Given this list of marker genes ASXL2, SYTL1, MICB, FGF22, HCRT, NHERF2, IL12A, LRRTM2, FCN2, HDGFL3, DLG3, LILRB1, SMAD3, ITGB7, C1QBP, DOK2, RIMBP3B, TAC3, NOTCH2NLA, RAET1E, FGF14, IBSP, DNAJA1, GNA12, GABARAPL3, PDGFC, IL6, F2RL1, PLXNB1, GNAT2, GPHN, ULBP2, FSHB, KCTD10, SCP2, TRDN, RGMA, FES, LTB, GDF3, VWDE, EFNA1, NMB, ECM2, IRS2, GRAPL, HLA-B, SCT, TGFB2, CD22, RASA1, GABARAP, CD177, PKD2, ARFGEF2, CCL1, ITGA4, NOTCH4, DKKL1, ENG, ARPP19, RIMBP3C, FST, MAF1, IL1RN, GBA1, DEFB106A, BID, SACS, SEMA6D, TMBIM1, HLA-F, TGFBR3L, KCNJ8, ESR2, LRP4, CXCL5, GPHA2, GMFB, LANCL1, ITGAX, ADRA2A, DMP1, GRB10 (NCBI Gene Id 9769), FNDC5, CR2, TAC4, RYK, IFNA10, BTNL10P, REG1A, FAP, WNT8A, MYO9B, S100A4, S100A9, RTP4, BTN3A3, TLR9, RIMBP3, ERBIN, FGF5, PMCHL2, IL17RA, OSGIN2, TUBB3, CHN1, SHANK3, UTS2B, HTR1A, TAP1, GDF9, SRPX2, S1PR2, DLL1, ANGPTL3, BTN3A2, CCKBR, GNRH2, SNX17, CMTM7, APLN, CD74, APOL2, GAST, BEX3, HOMER1, MYH9, BTN2A1, SH2B2, NEO1, ECM1, SLC39A1, ERBB3, GRN, IL36RN, NENF, CTSG, FRMD5, MR1, IGHA1, S100A13, PANX1, NRXN1, AIMP1, CASP8, BCAP31 (B cell receptor associated protein 31), SCGB3A1, CBLB, PLAUR, ERFE, TARM1, NGF, SLURP2, TRAF3IP2, SLC6A3, ELMO2, FZD1, ITGA2B, CD2, DTX1, ATP5F1B, TLR10, ZBTB16, FGF17, PENK, SLIT1, IGHG2, CD3G, HGF, LILRB2, GDF10 (growth differentiation factor 10), GRAP, COL5A1, PDYN, DKK2, ECRG4, GPRASP2, KITLG, CD8B, TGFBR3, EPHB2, ITGAD, NCK1, CASP3, DEFB1, FGF7, MAP3K7, EIF3A, BLK, RNF43, TAFA2, CCRL2, OSGIN1, CD36, MST1L, NCR3LG1, HBA2, DEFB106B, WNT7A, LGALS3, RELN, TAF6, MMRN2, JAKMIP1, WFIKKN1, NOTCH2NLB, SEMA5A, ITGA6, BTN1A1, TNFRSF14, DEFB103B, IL17D, IL7, S1PR3, PPBP, IL36B, CLU, CD8B2, TMED2, STC1, PECR, GDF5, ADAMTS13, ITPRID2, DEFB104B, ARNT2, DLG4, IL34, DUSP3, ULBP3, NPFFR2, SPG21, SEMA4A, SNX4, MUC4, PXN, IFNG, SEMA3G, EREG, SH2B1, AGTR1, PDCL3, NRXN2, ESM1, KLRC4-KLRK1, FRS3 (fibroblast growth factor receptor substrate 3), SPRED1 (NCBI Gene Id 161742), ENHO, TAPBP, CCL2, AKAP9, TNFRSF11B, IFNA7 (NCBI Gene Id 3444), BTNL2, DLG2, LGR6, LRIG2, S100A12, IFNE, EPS8L1, DMTN, IFNA6, TRAK2, PLXNC1, FGF1, CSPG5, NRROS, SOS1, MACC1, ACTN4, ANKRD13C, CASR, TRAK1, RAB8B, SOCS1, DAB2IP, SDCBP, ALCAM, IL27, PEX14, TRAF2, PTH, DDT, OXT (oxytocin/neurophysin I prepropeptide), USP33, LACRT, APP (NCBI Gene Id 351), BMP6, IZUMO1R, TSPAN8, METRNL, RASL11B, WNT9B, ADAM22, PTCH1, NTS, ADAM23, CCL23 (C-C motif chemokine ligand 23), GFRAL, LAMB1, CAV2, GABARAPL2, ISG15, FGF8, NPTN, CDNF, EFNA3, PRKN, REEP2 (NCBI Gene Id 51308), CD300LF, RSPO2, IGF1, APBB3, ITGB2, APOA1, GNA11, PACRG, LRPAP1, CCL13 (C-C motif chemokine ligand 13), PTPN11, TAP2, METRN, ASXL3, FADD, NF2, NXNL1, IGFL2, FERMT1, GNA13, TP53, TNC, HJV, GLMN (glomulin, FKBP associated protein), GRP, GRB14, SEMA4C, FBLN1, DEFB109B, SMURF1, SRMS, TNFSF13B, SEMA4B, GIP, RPGRIP1L (RPGRIP1 like), APOB, CCL26, NPY, TMED1, CMTM5, EFNA5, HOMER3, DGKQ, TNN, FGF23, CMTM2, GFRA3, HCK, BTNL8, FBN2, WNT6, FGF12, NECTIN4, LGALS1, IL17A, NICOL1, RAET1G, CALM3, KLB, ALKBH1, NTRK1, CRK, PTPN1, ADAM15, FABP4, ADM2, BDNF, TOR2A, CKLF, CXCL12, COL16A1, GNAI2, CD72, MAG, ADAMTS8, PDGFRA, LCK, PARK7, COMP, LRP12, VPS35, SOCS3, ERBB4, EGFL7, FN1, CNTFR, TRIM37, VAV3, IFNA14, WNT2, NCSTN, CCL4L2, DIAPH2, ITGAV, RNF41, WNT5B, TRAV29DV5, MARCO, PSEN1, PLA2G1B, ANKRA2, PTCH2, HMGB1, FZD8, SFRP2, ANKS1B, RIPK1, CXCL2, ZPR1, ICAM1, GDF6, TUBB4B, CBLC, IL10, SYT1, TOLLIP, RIC3, VTN (NCBI Gene Id 7448), APOC3, MTSS1, NXPH3, HIP1, COLEC10, IL33, CTHRC1 (collagen triple helix repeat containing 1), PPP1R9B, ULBP1, TRAF4, MRAP2, EMILIN1, TSLP, CHRNA10, NDP, CER1, CX3CR1, CD9, HLA-DRB1, ABL1, GPRC5B, FCER2, SHANK2, IL36A, DERL1, FLRT3, IGHD, SHISA6, NRG4, LTBP1, USP4, GUSB, PTGER1, HSPA1B, SNX1, ADH7 (NCBI Gene Id 131), NSF, IL17B, CSF1, WNT2B, FRS2, DPP4, S100B, PTPRD, NCK2, LTBP4, INS-IGF2, REEP1, EDN1, NLGN3, WNT7B (Wnt family member 7B), MICOS10-NBL1, HBEGF, OSMR, TTR, RAPGEF2, LRRC32, RABEP1, TRIM25, ANXA1, IGFL3, ARHGEF1, DST, WNT9A (Wnt family member 9A), SEMA6C, LMBRD1, IL17F, REG3A, S100A7, ANAPC11, ATRNL1, CD244 (CD244 molecule), MAGI2, PCNA, EDA, CSH2, TNFSF10, ADM (NCBI Gene Id 133), IL1B, CGB1, ADRA2C, SHH, BMP8B, TRAT1, TNF, CCL14, GNAI1, RASGRF1, HSPA8, MBL2, PIK3CG, HBA1, TSPAN4, SCYL2, MDK, CRP, ITGB4, ITGA9, GFRA1, ADRB1, TAF4, RER1, ADAM8, SELPLG, BOK, S100A8 (S100 calcium binding protein A8), HCST, CFC1, RACK1, CREB3, NGEF, CCR2, MRAP, C5, AP2A1, CASP8AP2, IL1RAPL1, NPPB, WNT4, PHIP, ADAM10, BTNL9, CISH, CCL8, TMEFF1, BANK1, ADIPOQ, CHAC1, UBXN2A, ADAM2, KISS1, ERAP1, BTN2A2, SMO, IGFBP2, ASIP, GALP, IGFBP1, NXPH2, WNT3A, TFF1, FLOT1, FKBP1B, EGF, TSHB, MIF (NCBI Gene Id 4282), RTP3, TSNAX (NCBI Gene Id 7257), ITGAL, PMCH, CCL3L3, PLPP3, FLNA, CDH26, ITGB1BP1, APOE, BBS1, PROK1, GLA, IGFBP7, DKK1, ZNRF3, DOCK2, CFL1, BAG6, SIVA1, JAM2, FGFR1, SOCS2 (suppressor of cytokine signaling 2), C1QTNF9, ANGPTL8, FIZ1, PRDX5, ANO1, EFEMP1 (EGF containing fibulin extracellular matrix protein 1), LY6E, UNC93B1, GAB4, NRXN3, RETNLB, PGR, MIA (MIA SH3 domain containing), BDKRB2, PITPNM2, GPI, SNX5, ANGPT1, KDR, CCN4 (NCBI Gene Id 8840), IL17C, IFNA1, TFF2, CPE, IL32, FPR1, FAM3D, HSP90AA1, IL2, IL20, PILRB, MAP7, GFAP, CCDC88A, NTF3 (NCBI Gene Id 4908), JAML, PLG, JAG1, BMP2, MARCHF1 (membrane associated ring-CH-type finger 1), FGF20, CDH5, TYMP, ANGPTL2 (angiopoietin like 2), CAPRIN2, POMC, LPL, VIP, IL25, WIF1, PTK2B, BMP5, CCL20, THBS4, SRI, BLNK, AVP, LYN, ITGAE (integrin subunit alpha E), ARHGEF12, AGT, PF4V1, NISCH, SCUBE3, PIK3IP1, GDF2 (growth differentiation factor 2), INSL5 (insulin like 5), CXCL9, MARCHF8, CNRIP1, IL1F10, HLA-C, PYY, LILRA4 (NCBI Gene Id 23547), IFNA8 (interferon alpha 8), FAM3C, DKK3, HMGB2, APOA2, RARA, NARS1, IL3, BEX1, HLA-A, CCL4, CXCL11, DEFB110, LCP1, SHANK1, CLPTM1, VAV2 (vav guanine nucleotide exchange factor 2), EDN3, CXCL6, GSK3A (glycogen synthase kinase 3 alpha), SEMA4F, SEC14L1, CXCL16, NR0B2, BMP8A, LAMB2, UCHL1, KCNA5 (NCBI Gene Id 3741), PALM, AIP, GKN1, GDF1, LDLRAP1, CFC1B, NPB, NECAB2, CTNNB1, SYTL5, LINGO1, CCN3, ANGPTL1, PTPN4, CXCL13, LAMA4, VCAM1, CMTM1, LYPD1, S1PR1, ITGA7, PGF, INHBC, PYY3, DNER, NOTCH1, IL9, IGHG3, PITPNM1, CRTAM, LTA, CALCB, SYTL4, ITGAM, JAK3, HIF1AN, HOMER2, SVEP1, SFRP1, CCL21, CLSTN3, MSMP, PTPRZ1, WNT3, F2RL2, IGFL1, CMTM8, BTN3A1, CMTM3, CCN2, SEMA6B, IL12B, NPVF, FER, PILRA, DEFB130B, CCL5, CADM4, NLGN2, GABRG1, MT-ND2, BMP3, TULP3, IRS1, SOCS5, PLA2G2C, CLEC7A, LEFTY1, CX3CL1, FERMT3, CCL16, GHRL (ghrelin and obestatin prepropeptide), CRKL, IL12RB1, CYTL1 (NCBI Gene Id 54360), EMP2, CACNG2, AMBN, ARRDC3, ARHGEF16, LGI1, TLR2, NPNT, SYK, ASXL1, PLAT, ITGB6, IL21, ITGA1, WNT11, GAL, SPRED2, SEMA3F, SHC2, STX1B, HLA-H, TSPOAP1 (TSPO associated protein 1), MED1, SSTR3, ARHGEF11, ICAM4, CGB2, EGFL8, RETN, PROK2, RLN2, HNF4A, GRK2, TNFSF13, IL1R1, FGF2, CCK, RNF135, TNFSF15, TCIM, DEFB4A, IFNW1, TIGIT, CGB3, PLCG1, BABAM2, IFNA2, DLG1, MFGE8, MADCAM1, DVL3, IGFL4, INSL6, CD4, SHC1, EDIL3, P2RX7, YES1 (NCBI Gene Id 7525), CNIH2, APLP1, YARS1, FZD7, TRIP6, PTK6, CYRIB, ICAM3, ARRB2, IL17RC, C1QTNF12, MYD88, IGSF1 (NCBI Gene Id 8696), CD70, AGRP, IGHG4, CACNG3, BEX2, NLGN4X, DNAJA3, PRMT2, SHC3, FBN1, CCL22, TRBV7-9, APOA5, NRIP1, CCL11, NODAL, SEMA6A, CXCL3, NCOA2 (nuclear receptor coactivator 2), PDGFB, TAFA3, AQP1, CPNE3, UCN3 (NCBI Gene Id 114131), PIK3AP1, FLRT2, FCRL6, NHERF1, GNAI3, FKBP1A, C7orf50, SNED1, SYTL2, FCN3, GLG1, EPGN, F2R, GNA14, UCN, ENSA, SHISA7, CLEC11A, ALKAL1, SLURP1, CXADR, ELAPOR2, CCDC88C, PTHLH, SQSTM1, CXCL8, NES, CLIC6, IFNL3, TGFBI, PVR, F7 (NCBI Gene Id 14068), HYAL2, FGF13, A2M, ARRB1 (NCBI Gene Id 408), SLC6A4 (NCBI Gene Id 6532), GREM2, HSP90AB1, SPP1 (NCBI Gene Id 6696), CUL3, SERPINE2, APOF, RIT2, FGR, TAOK2, LIFR, FASLG, C1QL1, PTPA, SCG2, CD40LG, AP2M1, SORBS1 (sorbin and SH3 domain containing 1), THBS1, OPHN1, LEPROT, BGLAP, SST, IGHM, IL4, CGB7, XCL2, CD226, WNT10A, TNFSF4, DUT, CCL15, IL26, FYB1, LGALS9, TRAV8-4, LGALS8, IFNA5, WFIKKN2, CCL24, EFNA2, DDX54, DBI, BMP10, GNAL, STAT1, CSHL1, APBB1, JAM3, MANF, TNFSF9, IGHG1, RSPO4, CNOT9, ARAP1, TG, HFE, HSP90B1, CD80, STAP1, RTP2, ACTN2, IGHE, EFNB1, ANGPT4, PNOC, ZDHHC17, ILK, CCL18, SNX6, IL36G, PIK3R2, SEMA3C, LAMA5, BICD1 (BICD cargo adaptor 1), BMP4, CD276, EBI3, CCL25, ITGB8 (NCBI Gene Id 3696), CCN6, LEFTY2, EDN2, TRAV19, CD81 (NCBI Gene Id 975), TRBV12-3, NPPA, FNTA, VEGFB, TAFA4, YWHAG, IRS4, IGSF11, DAND5, TLR6, NAMPT, CADM1, FGF10, IKBKB, LY6H, NLGN1, IL19, BMP1, BMP7, INSR, MICA, WIPI1, ITGA3, STRAP, NRG1, PHB1, LAMA3, GABARAPL1, ADORA1, ITGA11, KIR3DL2, GH1, NPFF, TENM2, NTN3, IFNA21, CRIPTO3, GCG, FLRT1, IL22, BAMBI, CCL19, TGFB1I1, TRAP1, IFNA17, MAGI3, CCL3 (C-C motif chemokine ligand 3), CD58, CD8A (CD8 subunit alpha), C1QTNF4, GRK3 (NCBI Gene Id 157), VEGFC, INHA, TGFBRAP1, MCHR1, UCN2, CFLAR, GRIPAP1, GNAO1, KLRK1, MLN, PICK1, HDGF, CGA, FGF16, P2RY2, INS, EFNA4 (NCBI Gene Id 1945), YWHAH, PICALM, GAB2, ARR3, DAB2, RNF126, THPO, LAMA1, CALCA, ITGB5, SAA1, FGF19, CCL7, CASK, COL3A1, INSL4, IL5, LRP6, DSCAM, HMGA1, LEP, ERMAP, GUCA2A, TNFSF14, ACE, VEGFD, SYTL3, TBP, NETO1, ITCH, MADD, LHFPL4, SMARCD1, LYNX1, ANGPT2, IL31, PTPRJ, GNAZ, IL13, SEMA7A, CHUK, PRLH, FCN1, NETO2 (NCBI Gene Id 81831), ERBB2, SLA, UTRN, NECTIN2, CCNB1, ENDOU, CNIH4, VTCN1, P2RX4, PSCA, SLIT3, REN, ADAM28, HLA-E (NCBI Gene Id 3133), JAK2, UTS2, FGF6, PDZK1, INHBA, F2, PDCD6IP, IGF2, CD151, TNFSF18, ABCA12, TIRAP, HLA-G, BTNL3 (NCBI Gene Id 10917), BTN2A3P, VCP, DEFB114 (defensin beta 114), MESD, IFNL4, LCN1, GALNT11, ADCYAP1, IGFBP4 (insulin like growth factor binding protein 4), TLR1 (toll like receptor 1), SIPA1L1, GAS6, PDGFD, GNAT3, ACP4, ANKS1A, RARRES2, ITPRID1, PTPN14, JAK1, ITGA10, GPNMB, OPRK1, TYROBP, WNT16, USP20, GREM1, MOG, CD320, CDC42EP2, SMAD2, ACTN1, FPR2, IFNB1, TAFA5 (NCBI Gene Id 25817), ADAM9, TNXB, DLL3, NRG2, CLCF1, MEGF10, ITPRIPL1, MMP14, ENPP1, GABRB1, PPY (NCBI Gene Id 5539), FAM83B, NRTN, CD86, CCL28, ICAM5, PPIA, CDH17, WNT1 (Wnt family member 1), ADRB3, NXPH1, JAG2, AMELX, PF4, GDF7 (growth differentiation factor 7), COPA, RAPSN, SYNDIG1, TUB, TRH, ITGB1, IL24, NPPC, STUB1, GNAS, CCN5, USP15, TNFSF12, NCOR2, TGFB3, CNTF, TUBB, RTP1, LAG3, CD3E, FEM1B, ANG (NCBI Gene Id 283), ATP5F1A, PITPNM3, IL23R, F11R, CLTC, PTPRC, LAMA2, KLRD1, ADAMTS5, MST1, MYOC, TOB1, IL1A, EFNB3, WNT5A, OGN (NCBI Gene Id 4969), CRH, SEMA5B, ICOSLG, TGFA, DHH, GABRA5, CDK5R1, CRIPTO, FGF4, EFNB2, GRB2, DAZAP2, PDE4D, INHBE, STAT3, HAMP, CXCL10, THNSL2, FGA, BEX5, EPO, PDGFA, FGG, AREG, PPP2CA, C17orf99, CXCL14, PRNP, AMN, CSF2, VEGFA, CCL27, IHH, GDF11, IDUA, AKAP5, APELA, ITGB3, FBLN5, GRIA1, STOML2, CACNG4, RSPO3, GRM5, PGLYRP1, CSNK2B, PCSK9, HILPDA, PIDD1, PIK3R1, LY96, MPP1 (NCBI Gene Id 4354), BMP15, ITGA5, RND1, EPHA7, IGFBP6, NXPH4, TRIM24, ADORA2A, SELP, SNW1, ITGBL1, P4HB, SEMA3B, FLT3LG (fms related receptor tyrosine kinase 3 ligand), RLN3, JCHAIN, TRAF1, DEFB103A, TF, CAV1, LY6S, IFNA4, PTK2, NOG (NCBI Gene Id 9241), LRRC4B, OSM, PDGFRB, PRKCA, ARNT, FGB (fibrinogen beta chain), DNAJC14, HSPG2, ATXN2, NPW, IL16, FGF21, IFNL1, KIF5C, FERMT2, CHGB, DVL1, PSMC5, ARTN, NOL3, DRD2, TIMM50, CRLF1, SNX2, PRTN3, DLK2, S100A14 (NCBI Gene Id 57402), PSPN, PDZK1P1, ITGA2, MSN, NTF4, COL2A1, RIPK2, TRGV3, TACC1, VWF, XCL1 (NCBI Gene Id 92337), SEMA4G, SAG, TGFB1, AGR2, ZP3, SRC, EGFL6, AVPR1A (arginine vasopressin receptor 1A), TIMP1, CNIH1, CACNG8, PXDN, SEMA4D, ICAM2 (intercellular adhesion molecule 2), FYN, IGF1R, ALKAL2, IFNA16, CNPY4, STC2, RALA, GNAT1, CBL, VSTM1, SECTM1, SH2B3, TLN1, LHB, FGF18, ITGA8, SEMA3A, PIBF1, MYO1C, LIF, GNA15, TNFSF11, ABCA1, CD160, DIAPH1, SEMA3E, IFNK, GPHB5, PLSCR4, CAMK2A, TRPC1, IL23A, INSL3, IL37, DKK4, TAFA1, TLR4, DLL4, CIB2 (NCBI Gene Id 404086), FAM3B, THY1, TESPA1, IRAK4, DEFB133, ADA2, NMU, SMAD7, ADAM11, NRG3, ARMCX5-GPRASP2, IL6ST, FGF11, TRGV9, SNTG2, CDC42, TRADD, FGF9, ANGPTL6, PLSCR1, CNPY3, LRG1, IL18, TRAF6, EDNRB, CTF1, TNK2, IL15, AR (androgen receptor), SLIT2, CSF3, FEM1A, KIR2DS4, CNIH3, NEDD4, RHEX, C3, IGFBP5, BTC, AAK1, LRP1, IZUMO1, TGFBR1, CCL17, IL11, TLN2, KL, AMACR, OSTN, RLN1, CSH1, AGTR2, PLCL2 (phospholipase C like 2), SMARCD3, FRK, GATA3, ERN1, HSPA1A, TREM2, GDNF, DVL2, PYCARD, HLA-DRA, PTN, CLEC2B, SH3BP1, CDK5, TRAF5 (TNF receptor associated factor 5), WNT10B, MS4A1, GH2 (growth hormone 2), IKBKG, PRL, GIPC1, CLEC4D, SHC4, ANXA7, HRG, DOCK4, IL6R, IAPP, WNT8B, ADAM17, LBP (lipopolysaccharide binding protein), SERPINE1, HAP1, RABEP2, CARTPT (CART prepropeptide), TLR5, TNFSF8, NLGN4Y, NR1H2, IL18BP (NCBI Gene Id 10068), P2RY1, NSG1, OPRD1, AMH, NHERF4, TAC1, SPX, HHLA2, GNRH1, CD48, VGF, RTP5, FGF3, GPR17, SMAD6, QRFP, GNAQ, GMFG, SEMA3D, INHBB, CCN1, ITGB1BP2, CTNND1, GFER, PTPN2, TGFBR2, MDM2, GHRH (growth hormone releasing hormone), CD274, DEFB130A, ARF4, EPHA4, PDPN, TRAF3, DNAJB11, CXCL1, GDF15, NBL1, TYK2, IGHA2, MSTN, DEFB104A, PCSK1N, KNG1, ACTN3, COL4A3, RSPO1, CALR, CORT, BMAL1, GPR15LG, IFNL2, here is a description of the gene set: Human Gene Set: GOMF_SIGNALING_RECEPTOR_BINDING species: Homo sapiens Binding to one or more specific sites on a receptor molecule, a macromolecule that undergoes combination with a hormone, neurotransmitter, drug or intracellular messenger to initiate a change in cell function.